Given this list of marker genes PDPN, SLC25A32, FOLR3, SLC19A2, ABCC5, FOLR1, FOLR2, LRP2, SLC19A1, SLC46A1 (solute carrier family 46 member 1), here is a description of the gene set: studied in species Homo sapiens Human Gene Set: GOBP_FOLIC_ACID_TRANSPORT The directed movement of folic acid (pteroylglutamic acid) into, out of or within a cell, or between cells, by means of some agent such as a transporter or pore. Folic acid is widely distributed as a member of the vitamin B complex and is essential for the synthesis of purine and pyrimidines.